The following is a description of a gene set: Human Gene Set: HP_APLASIA_HYPOPLASIA_OF_THE_MIDDLE_PHALANGES_OF_THE_TOES Aplasia/Hypoplasia of the middle phalanges of the toes species: Homo sapiens, and this is the list of marker genes: ERF, VAC14, EOGT, NOG, IHH, RAB23, FIG4